The following is a description of a gene set: The chemical reactions and pathways resulting in the breakdown of monoacylglycerol, any ester of glycerol in which any one of its hydroxyl groups has been acylated with a fatty acid, the other being non-esterified. species: Homo sapiens Human Gene Set: GOBP_MONOACYLGLYCEROL_CATABOLIC_PROCESS, and this is the list of marker genes: ABHD12, ABHD12B, ABHD16B, ABHD16A, MGLL, ABHD6, FAAH